Given this list of marker genes ERAP1, GPCPD1, GRID1, HSD11B1, FAM47E, PDE8B, CECR2, PNO1, HERC4, VKORC1L1, PROX1 (prospero homeobox 1), SWT1, CDH9, HNRNPH1, PTGER4, MEF2C, ZNF12 (zinc finger protein 12), NCBP1, SH3GLB1, LRRC18, SYNE1, SALL1, FOXF1, CIMIP2B, NR3C1, IFT52, RBAK, DDX17, TYW5, GEN1, HDAC4, EIF1AX, PATL2 (PAT1 homolog 2), SLC1A7, DPP8, CTNNA1, COX20, HEPHL1, MAN1C1 (mannosidase alpha class 1C member 1), SLC44A5, EYA1, ZNF106, ZNF521, SAMD5, SATB2, CCT6B, PHIP, DENND6A, MTRF1L, TAF7L, SLC2A12, OPRM1, NFX1, UBR3, RBM7 (NCBI Gene Id 51120), CNTN1, PABIR3, SLITRK4, LPP, CSTF3, TWSG1, SGO2, here is a description of the gene set: studied in species Homo sapiens Genes predicted to be targets of miRBase v22 microRNA hsa-miR-3144-3p in miRDB v6.0 with MirTarget v4 prediction scores > 80 (high confidence targets). Human Gene Set: MIR3144_3P from publication Chen Y, Wang X (PMID 31504780)